The following is a description of a gene set: PPAR signaling Human Gene Set: WP_PPAR_SIGNALING species: Homo sapiens, and this is the list of marker genes: FABP1, MMP1, PDPK1, FABP3, ACSL1, CYP8B1, RXRG, PPARA, NR1H3, CPT2, DBI, CPT1C, PLTP, APOC3, SLC27A4, APOA2, SORBS1, ACAA1, SCD, EHHADH, HMGCS2 (3-hydroxy-3-methylglutaryl-CoA synthase 2), AQP7, ACOX1, SLC27A5, PPARG, CYP27A1 (NCBI Gene Id 1593), RXRA, ILK, SCP2, CD36, GK (glycerol kinase), ANGPTL4, FADS2, ADIPOQ, LPL, FABP4, APOA5, PLIN1, APOA1, PCK1, UCP1, CYP4A11, CYP7A1, ME1, OLR1, SLC27A1 (NCBI Gene Id 376497), PCK2, UBC, RXRB, PPARD